Given this list of marker genes ALDH6A1, HIBCH, ACAD8, BCAT2, BCKDK, HIBADH, here is a description of the gene set: Human Gene Set: GOBP_VALINE_METABOLIC_PROCESS studied in species Homo sapiens The chemical reactions and pathways involving valine, 2-amino-3-methylbutanoic acid.